The following is a description of a gene set: CD4 T from publication He P, Lim K, Sun D, Pett JP, Jeng Q, Polanski K, Dong Z, Bolt L, Richardson L, Mamanova L, Dabrowska M, Wilbrey-Clark A, Madissoon E, Tuong ZK, Dann E, Suo C, Goh I, Yoshida M, Nikolić MZ, Janes SM, He X, Barker RA, Teichmann SA, Marioni JC, Meyer KB, Rawlins EL (PMID 36493756) Human Gene Set: HE_LIM_SUN_FETAL_LUNG_C4_CD4_T_CELL species: Homo sapiens, and this is the list of marker genes: CHI3L2, ICOS, SOCS3, LINC01550, LRRN3, THEMIS, ACTN1, ARMH1, TMEM204, CTSL, FKBP5 (NCBI Gene Id 2289), FHIT, PASK, LIMS2, CD40LG, RCAN3, SERINC5, FCGRT, CD6, RAB25 (NCBI Gene Id 57111), CSGALNACT1, TRAT1 (NCBI Gene Id 51488), IL6ST, INPP4B, CD5, CCR7, BACH2, SIT1, SUSD3, EPHX2, CD4, GPR183, MAL